The following is a description of a gene set: electronically inferred by orthology from the curated human pathway part of: Regulation of CDH11 Expression and Function This event has been computationally inferred from an event that has been demonstrated in another species.<p>The inference is based on the homology mapping from PANTHER. Briefly, reactions for which all involved PhysicalEntities (in input, output and catalyst) have a mapped orthologue/paralogue (for complexes at least 75% of components must have a mapping) are inferred to the other species. Reactome Pathway: Regulation of CDH11 gene transcription studied in species Mus musculus, and this is the list of marker genes: Ilf3